Given this list of marker genes ADORA2A, OPHN1, IGSF11, SHANK2, NHERF2, PTK2B, CAMK2A (NCBI Gene Id 815), NETO1, PRNP, DLG4, NETO2, SHISA7, GNAS, CACNG3, DLG1, GRIPAP1, CACNG8, NEDD4, GRIA1, DRD2, NSF, MT-ND2, NSG1, NHERF1, HOMER1, SRC, NECAB2, SQSTM1, SHISA6, FYN, SYNDIG1, CACNG2, CALM3, HOMER2, CDK5R1, DLG3, CACNG4, PTPN4, RASGRF1, DLG2, AKAP5, HIP1, RAPSN, HOMER3, SHANK1, SHANK3, FLOT1, here is a description of the gene set: Human Gene Set: GOMF_GLUTAMATE_RECEPTOR_BINDING Binding to a glutamate receptor. studied in species Homo sapiens